The following is a description of a gene set: Mouse Gene Set: GROSS_HYPOXIA_VIA_ELK3_ONLY_UP Genes specifically up-regulated in SEND cells (skin endothelium) at hypoxia after knockdown of ELK3 by RNAi. species: Mus musculus The ternary complex factor Net/Elk3 is downregulated in hypoxia and participates in the induction by hypoxia of several genes, including c-fos, vascular endothelial growth factor and egr-1. However, the global role of Net in hypoxia remains to be elucidated. We have identified, in a large-scale analysis of RNA expression using microarrays, more than genes that are regulated by Net in hypoxia. In order to gain insights into the role of Net in hypoxia, we have analysed in parallel the genes regulated by HIF-1alpha, the classical factor involved in the response to hypoxia. We identified about genes that are regulated by HIF-1alpha in hypoxia. Surprisingly, when we compare the genes induced by hypoxia that require either Net or HIF-1alpha, the majority are the same (75%), suggesting that the functions of both factors are closely linked. Interestingly, in hypoxia, Net regulates the expression of several genes known to control HIF-1alpha stability, including PHD2, PHD3 and Siah2, suggesting that Net regulates the stability of HIF-1alpha. We found that inhibition of Net by RNAi leads to decreased HIF-1alpha expression at the protein level in hypoxia. These results indicate that Net participates in the transcriptional response to hypoxia by regulation of HIF-1alpha protein stability. from publication Gross C, Dubois-Pot H, Wasylyk B (PMID 17704799), and this is the list of marker genes: Pgm1, Eprs1, Nfil3, Spag9, Gadd45a, Cebpb, Egln1, Slc7a11, Apba3, Amotl2, Naip2, Herpud1, Egln3, Rnd3, Clec4e, Ppp1r15a, Slc20a1, Cxcl2, Rabgef1, Cxcl5, Dhrs9, Fst, Ch25h, Gspt2, Adm, Atf4, Pdlim5, Ascc2, Il6, Lcp1, Rapgef2, Slpi, Akap12, Thbd